Given this list of marker genes SYNJ1, SLC12A5, TRNT1, YARS1, GATA2, SLC22A12, CACNB4, SCN4A, NDUFS2, KCNJ11, ATP6AP2, ENG, SOST, FIG4, TP53, CHRNA1, JAK2, ATP7B, C14orf39, GRN, RNASEH1, here is a description of the gene set: Onset of disease at an age of greater than or equal to 19 to under 25 years. Intermediate young adult onset Human Gene Set: HP_INTERMEDIATE_YOUNG_ADULT_ONSET species: Homo sapiens